The following is a description of a gene set: Human Gene Set: MODULE_514 species: Homo sapiens Genes in the cancer module 514., and this is the list of marker genes: DHRS2, ADH1A, ADH7, SORD, TP53I3, ADH4, CRYZ, CRYZL1, FASN, ADH1C